The following is a description of a gene set: Human Gene Set: MIR6794_3P from publication Chen Y, Wang X (PMID 31504780) studied in species Homo sapiens Genes predicted to be targets of miRBase v22 microRNA hsa-miR-6794-3p in miRDB v6.0 with MirTarget v4 prediction scores > 80 (high confidence targets)., and this is the list of marker genes: PCDHA4, FBXW7, MAP3K13, ZNF737, PCDHA2, PHF2, EPHA7, PCDHA9, RFX3, TIMM8B, PRELID3B, TRMT12, PCDHA11, GRK2, C3orf33, ANKRD12, DNAH11, ELP1, IDH3A (isocitrate dehydrogenase (NAD(+)) 3 catalytic subunit alpha), TGFBR3, ZNF780A, ELAVL1 (NCBI Gene Id 1994), SNUPN, FIP1L1, CAMKK2, PCDHA3, ZNF569, PCDHAC2, YPEL5, UBE2D3, HECW2, USP37, ELAC1 (elaC ribonuclease Z 1), QSER1, SCN9A, SLC2A2, SLC6A5, PCDHA10, TLNRD1, NPAT, RNF41, NXF1, PCDHA6, ELF1, MAP4K3, HOMER1, CPSF2, PCDHA1, YPEL4, CA3, FBXW10B, OXTR (oxytocin receptor), LEMD3, CADM1, CBLB, ATP6AP2, CD59, SLC26A4, DENND11, PON2, IL17RD, PCDHA8, TSPAN5, ZNF626, DCAF8, TNPO1, PCDHA12, NSG1, WAC, PSME4, DLG4, PCDHAC1, PCDHA7 (protocadherin alpha 7), GFI1 (NCBI Gene Id 2672, growth factor independent 1 transcriptional repressor), STARD9, PCDHA5, PRR5L, SLC12A8, ARIH1, CTAGE1, UQCC1, FKBP1B, APOBEC1, PCDHA13, FBXO48